Given this list of marker genes DEPDC1B, DNMBP, ARHGDIA, TMPO, CDC42SE2, PREX1, WDR81, SRGAP2, FGD4, ARHGAP29, ITSN1, ARHGEF15, PIK3R1, PAK6, STARD13, GMIP, TAGAP, FGD3, ARHGAP24, VAMP3, STOM, ARHGEF11, STEAP3, GIT1, PLEKHG3, DOCK11, ARHGAP17, CDC42EP2, ARHGAP42, ARHGAP4, ABR, WIPF2, ARAP1, VAV3 (NCBI Gene Id 10451), CAV1, DOCK10, ARHGEF4, RACGAP1, ECT2, PAK1, ARHGDIB, NGEF, ARHGDIG, SRGAP1, LAMTOR1, CDC42, SHKBP1, DOCK8, PLEKHG4 (NCBI Gene Id 6312), FARP1, ARHGEF7, MAP3K11 (NCBI Gene Id 4296), WIPF1, ARHGAP30, ARHGEF6, BAIAP2, FGD2, ARHGEF10, DOCK9, ARHGAP40, SNAP23, ARHGAP45, CDC42EP5, ARHGEF26, DLC1, ARFGAP2, WIPF3, GOLGA8R, ARHGAP1, SYDE1, GNA13, IQGAP3, TRIO, ARFGAP3, CDC42EP3, DAAM1, FMNL1, DOCK7, CHN1, FAM13B, ARHGAP32, ARHGAP31 (Rho GTPase activating protein 31), TIAM1, MCF2L, ARHGEF5, DOCK6, ARHGAP27, SPATA13, ARAP2, BCR, PLEKHG4B, ARHGAP44, FGD1, SRGAP3, WDR91, SH3PXD2A, CDC42EP1 (CDC42 effector protein 1), ARHGAP33, CPNE8, ARHGAP22, VANGL1, PREX2, STARD8, KTN1, ARHGAP9, IQGAP2, ARAP3, ARHGAP5, DIAPH3, CDC42BPB, ARHGEF12, ARHGEF19, IQGAP1, CDC42BPA, ARHGAP35, KCTD3, RAB7A (NCBI Gene Id 7879), FNBP1L, VAV2, ARHGAP10, SCRIB, FNBP1, MCF2, PAK2, FMNL3, YKT6, ARHGAP20, PAK5, ARHGAP39, ARHGAP11B, PLD1, PIK3R2, JUP, ARHGEF9, PLEKHG1, ARHGAP21, RALBP1, ARHGAP26, ARHGEF16, CDC42EP4, WASL, PAK4, WAS, OPHN1, PAK3 (p21 (RAC1) activated kinase 3), GIT2, ARHGEF25, FMNL2, PLEKHG2, DEF6, TFRC, RASGRF2, LBR, MYO9B, PARD6A, here is a description of the gene set: CDC42 GTPase cycle species: Homo sapiens Human Gene Set: REACTOME_CDC42_GTPASE_CYCLE